The following is a description of a gene set: species: Homo sapiens Human Gene Set: GOBP_ICOSANOID_CATABOLIC_PROCESS The chemical reactions and pathways resulting in the breakdown of icosanoid., and this is the list of marker genes: LYPLA2, CYP4F2, DPEP1, CYP4F3, CYP4A11, DPEP2, CYP4F12, ABHD16A (NCBI Gene Id 7920), HPGD